The following is a description of a gene set: Oxidized phospholipids are thought to promote atherogenesis by stimulating endothelial cells (ECs) to produce inflammatory cytokines, such as IL-8. In studies with mouse models, we previously demonstrated that genetic variation in inflammatory responses of endothelial cells to oxidized lipids contributes importantly to atherosclerosis susceptibility. We now show that similar variations occur in cultured aortic ECs derived from multiple heart transplant donors. These variations were stably maintained between passages and, thus, reflect either genetic or epigenetic regulatory differences. Expression array analysis of aortic EC cultures derived from 12 individuals revealed that >genes were regulated by oxidized phospholipids. We have used the observed variations in the sampled population to construct a gene coexpression network comprised of 15 modules of highly connected genes. We show that several identified modules are significantly enriched in genes for known pathways and confirm a module enriched for unfolded protein response (UPR) genes using siRNA and the UPR inducer tunicamycin. On the basis of the constructed network, we predicted that a gene of unknown function (MGC4504) present in the UPR module is a target for UPR transcriptional activator ATF4. Our data also indicate that IL-8 is present in the UPR module and is regulated, in part, by the UPR. We validate these by using siRNA. In conclusion, we show that interindividual variability can be used to group genes into pathways and predict gene-gene regulatory relationships, thus identifying targets potentially involved in susceptibility to common diseases such as atherosclerosis. Human Gene Set: GARGALOVIC_RESPONSE_TO_OXIDIZED_PHOSPHOLIPIDS_CYAN_UP Genes from the cyan module which are up-regulated in HAEC cells (primary aortic endothelium) after exposure to the oxidized 1-palmitoyl-2-arachidonyl-sn-3-glycerophosphorylcholine (oxPAPC). from publication Gargalovic PS, Imura M, Zhang B, Gharavi NM, Clark MJ, Pagnon J, Yang WP, He A, Truong A, Patel S, Nelson SF, Horvath S, Berliner JA, Kirchgessner TG, Lusis AJ (PMID 16912112) studied in species Homo sapiens, and this is the list of marker genes: CREBRF, GSR, CDK17, TFE3, USP12P1, ADAM17, CCDC117, SETD5, PTGER4, PSEN1, PTP4A1, AKIRIN2, CITED2, ARF6, SLC7A1, GNA13, CSGALNACT2 (NCBI Gene Id 55454)